The following is a description of a gene set: Human Gene Set: HP_BILATERAL_SENSORINEURAL_HEARING_IMPAIRMENT A form of sensorineural hearing impairment that affects both ears. species: Homo sapiens Bilateral sensorineural hearing impairment, and this is the list of marker genes: SQSTM1, MRAS, STRC, COA8, KCNE1 (potassium voltage-gated channel subfamily E regulatory subunit 1), CD109, MT-TV, MT-TS2, VCP, MT-TC, RNF113A, MPLKIP, PSAP, ATP6V0A4, MT-CYB, IARS2, TARS1, NARS2, MT-CO1, MPEG1, IGF1, DSPP, GTF2H5, GP1BA, RRM2B, MT-TK, LHFPL5, ADAMTSL1, POGZ, POLG, SLC12A2, MAP3K20, MT-CO2, ITGA2, ERCC3, CLCNKA, ARSA, MARS2, GP1BB, FUS, ATG7, MT-TL1, MT-CO3, GTF2E2, DNAJC3, RBMX, BSND, ATP6V1B2, CATSPER2, MT-TQ, TBK1, COL4A3, GRXCR2, MYH14, YARS1, MYO7A (NCBI Gene Id 4647, myosin VIIA), SOX2, NAXD, AARS1, SIX6, COL4A6, SPTBN1 (spectrin beta, non-erythrocytic 1), KCNQ1, ITGB3, TWNK, LETM1, POU3F4, CLCNKB, TUBB3, ERCC2, MAP1B, MT-TF, TBC1D24, TARDBP, MT-ND1, CARS1, DNAJC19, ACTG1, CHCHD10, ITGA2B (NCBI Gene Id 3674), ACOX1, LOXHD1, MT-TW, MT-ND5, MT-ND6, CHSY1, RTTN